The following is a description of a gene set: This event has been computationally inferred from an event that has been demonstrated in another species.<p>The inference is based on the homology mapping from PANTHER. Briefly, reactions for which all involved PhysicalEntities (in input, output and catalyst) have a mapped orthologue/paralogue (for complexes at least 75% of components must have a mapping) are inferred to the other species. electronically inferred by orthology from the curated human pathway Reactome Pathway: Signalling to ERK5 studied in species Mus musculus part of: Signaling by NTRK1 (TRKA), and this is the list of marker genes: Mapk7 (mitogen-activated protein kinase 7)